Given this list of marker genes SPI1, HMCES, IL6, TICAM1, TNFRSF13C, STAT5A, TIRAP, WNT3A, TLR4, GPR183, VAV3, PTPRC, IL7, IL4, IL21, CD81, SYK, SH3KBP1, IL10, PMS2, PELI1, EXOSC3, STAT6, NCKAP1L, FCRL3, BCL2, SLC39A10, MAD2L2, DDRGK1 (DDRGK domain containing 1), PPP2R3C, CD40 (NCBI Gene Id 958), KMT5B, IL5, SHLD3, MMP14, ADA, TBX21, CLCF1, TP53BP1, BTK, SHLD1, INPP5D, TFRC, SHLD2, KMT5C, PCID2, NSD2, PAXIP1, ATAD5, CD28, STAT5B, EPHB2, MLH1, MIF, TGFB1, EXOSC6, TNFSF4, TNFSF13B, AKIRIN2, NOD2, CARD11, TNFRSF4, CD38, RIF1, SASH3, CD320, IL2, BCL6, BMI1, XBP1, IL2RG, CDKN1A, CD74, TNIP2, TNFSF13, TLR9, BST1, IRS2, PRLR, MSH2, IL13, MEF2C (NCBI Gene Id 4208), CD27, NFATC2, CHRNB2, BAD, TCF3, here is a description of the gene set: Any process that activates or increases the frequency, rate or extent of B cell activation. species: Homo sapiens Human Gene Set: GOBP_POSITIVE_REGULATION_OF_B_CELL_ACTIVATION